Given this list of marker genes MAPK1IP1L, FOXL2NB, NEK2, GOSR2, SLC6A11, SATB2, PNPO, AAK1, C16orf54, CEP97, ETFBKMT (NCBI Gene Id 254013), MATR3, SYT4, CNTLN, LPGAT1, GINS1, IRF9, MYO5C, EFR3B, TSPAN2, FZD3, ORAI3, PNISR, TMEM170B, GNS, SERTAD2, IRF4, ALG1, CISD2, CDC5L, EEA1, TVP23A, C2orf49, CYP20A1, PSPH, H6PD, FDXACB1, ALDH18A1, RLIM, TKT, PIK3CA, GPI, SULT1E1, PPM1A, ZSWIM4, INTS6, TMEM52B, TRAPPC2, IGF2BP3, SLC4A8, SULT1C4, PAIP2B, PSTPIP2, MTPAP, SLAIN1, ZNF839, ZCCHC14, DCUN1D1, THUMPD2, FBXW2, HP1BP3, NPAP1, ZC3H6, CCL16, AMER2, KCNJ14, RPP30, TAS2R14, HUS1 (NCBI Gene Id 3364), RPS27L, CRIPTO, INMT, LEPROTL1, GOLM2, ZNF281, AS3MT, GLG1, AKR1D1, GRSF1, RBM8A, IFI6, PARD6B, CYP51A1, ARID5B, SLC5A5, SMC1A, SIKE1, MTFMT, UBE2W, EDEM1, KIF18B, OSBPL10, PIWIL1, CASTOR2 (NCBI Gene Id 730322), TOPORS, CBX5, REPS2 (NCBI Gene Id 9185), PRR27, ALDH16A1, TANGO2, DOCK1 (dedicator of cytokinesis 1), HELLS, EPB41L4A, SCIMP, ELAVL2, ZNF426, KL, MDM2, DUSP19, TMEM120B, FAM228B (family with sequence similarity 228 member B), HIF3A, SCARF1 (scavenger receptor class F member 1, NCBI Gene Id 8578), ZC3H13, RASSF5, STON1, DCUN1D2, TVP23C, CHSY3, WDR44, RBBP4, FBXL20, ZNF286B, COX15, PIGR, XPNPEP3, CHSY1, KRT222, MYLK4, SVBP, TLCD4, MOB1A, ZNF816-ZNF321P, APOL2, CREB1, SKA2, ZNF611, PTEN (NCBI Gene Id 8037), GTPBP3, NLRC3, KRIT1, HIGD1A, TRAF3IP1, TRIM59, FAM234B, HDAC2, PITPNM2, CHP1, RAB33B, EEF1AKMT3, PCDH10, DTX3L, EXOC5, SLC36A2, PSMD12, PURB, ZNF552, ENAH, WDR5B, ATP6V0A2, ZNF454, TNFSF9, KRR1, DNAL1, PDZD8, MED17, DHRSX, TMX1, NLK, ZNF780B, RBM43, MORN4, NIM1K, SLC8A1, SSX2IP, KBTBD6, KLF5, BAZ1A, POLR1G, TASOR, APOL6, SLC41A2, SLU7, ZSWIM1, ZNF850, VIP, UPK3BL1, STRADB, RTKN2, PGR, PPP1R15B, NUGGC, PLEKHA5, NCAPG2, BVES, FRG2C, SLC15A5, ZNRF3, RETREG3, RAB11A, ST8SIA4, C2orf69, HEG1, TM4SF20, SPACA9 (sperm acrosome associated 9), ZNF260 (zinc finger protein 260), PI4K2B, ZBTB2, CDCA7L, KIN, PDK3, SNTB2, SERPINB8, LRPPRC, MCM4, TLCD2, TOGARAM1, RTCA (NCBI Gene Id 8634), COLEC10, CYP4F3, RHNO1, MAVS, AIFM2, POLR2J3, DCP2, CBX6, MGA, MRPS30, FAM20B, PDE7A, SGCB, FYB2, UQCC3, TMEM184C, PAFAH1B1, HAVCR2, ZCCHC8, FGD5, CSGALNACT2, USP33, TPM3, ARCN1, ZNF326, TFAP2C, FLRT2, ZMYM6, ISL1 (ISL LIM homeobox 1), WAC, EEF1A1, DCAF17, PPM1D, ARL6IP1, TOR1AIP2, TRMT9B, EIF2S3, GABRP, DCUN1D5, LSM8, MYO3B, SALL4, CRCP, ICE2, TBK1 (NCBI Gene Id 29110), TIMM50 (translocase of inner mitochondrial membrane 50), CFL2, ZNF626, SINHCAF, RASGRP4, PIP4K2A, RRP15, OSMR, GPR37L1 (G protein-coupled receptor 37 like 1), SLC35E2A, GALNT12, GCM1, ZNF530, MFSD4A, PPFIBP1, OR2H1, MRPS16, TRPM6, TSPYL1, CHD6, TFDP2, S1PR5, TCF7, SCD, ELF5, RHD, SDHA (NCBI Gene Id 6389), ALDH6A1, LETM1, CENPA, DBT, ZC3H12B, POU2F3, KLF8, ZFP14, ARPIN, KHDRBS2, AIG1, UTP25, ACOX1, TAS2R20, PCBD2, ZNF793, NMNAT1, SLC19A4P, VIPR2, HMBOX1, VCPIP1, SUMF2, ZNF736, BPNT2, ACTR2, KPNA4, STAM, CA8, BCL10, TXNIP, HAUS5, ARL17A, RAD51AP2, MOB3B, RARS2, ILDR2, SNX22, SERPINB9, CACNG4, GOLGA3, MYLK3, CALCB, KIF3A, COLCA1, GXYLT1, TXNL4B, SURF4, GLB1L3, RNF125, PLAC8, BBIP1, SCD5, KPNA3 (NCBI Gene Id 3839), CEP72, CEBPB, AP1G1, NDUFV3, SLC48A1, COMMD8, FNBP4, DUSP3, ZNF486, ARGFX, GCSAML, SLC25A34, WDR27, PDE12, ZSCAN9, ABHD18, PTCHD4, ERCC6L2, CEACAM8, ZNF493, MEFV (NCBI Gene Id 4210), SLC15A1, ZNF814, EMC1, EMP2, ZBTB7A, TWF1, TXNDC9, MRPL19, TMED5, ADPRH, TMEM239, SH3TC2, LRRC47, PAICS, FZD2, FTO, MS4A10, FGFBP3, HS3ST3B1, FAM111A, RIMKLB, ELOVL5, TGS1, ZFP36L2, HOOK3, FXN, CEBPZOS, NOM1, RRM2, NDUFC2, SNX1, SDE2, POLH, EPHA3, USF3, AP4S1, RTBDN, INHBE, TENM2, GNG4, TNS4, ALG9, TIPRL, GNG2, CSDE1, RNF207, NHLRC2, ZNF101 (zinc finger protein 101), DIAPH2, VPS26A, ZNF785, SMAD4, MTR, PTGIS, ACKR2, RNF8, BRIP1, PRELID2, KALRN, NF2, ZNF286A, CDKL5, BRD2, TMEM167B, CCNJ, ZNF587B, PPAT, RAP1A, CR1, TMED4 (NCBI Gene Id 222068), SPATS2L, SLC9A7, ACYP2, INPP5B, RAD52, GTF2IRD2B, TMEM106B, MTX3, SV2B, FAM210A, CCNY, ADAMTS4 (ADAM metallopeptidase with thrombospondin type 1 motif 4), ZNF124, CSTF2T, VHL (von Hippel-Lindau tumor suppressor), HECW2, CILK1, HPSE, CAMLG, CDX1, GM2A, SMIM17, TMEM59, METTL8, PWWP3B, ZNF805 (zinc finger protein 805), RAD54B, ALKBH5 (NCBI Gene Id 54890), SLC25A32, SPRYD4, RPL15, SLC2A4 (NCBI Gene Id 6517, solute carrier family 2 member 4), FAM204A, KIF16B, GEMIN5, MAP4, ATL3, TMEM41B, TERF2, ZMYM1, PRTG, MFSD8, UBE2V2, ZNF699, PDE6B, SYNJ2BP, ARHGAP5, LY75, MPV17L, SDC2, APRG1, OLFML1, GRM3, TSNAX, SPECC1, HRH4, CDH6, FCAR, ZNF765 (NCBI Gene Id 91661), DAND5, PAPLN, HTR1D, CBL, WDR76, POLR2J2, TRDN, ELK4, CNBP, CFAP210, APOOL, FGF14, C19orf12, RBL1 (NCBI Gene Id 5933), ZBTB3, THAP5 (NCBI Gene Id 168451), PCDHB16, ATP13A4, SIX4, PHF20L1, SH3BGRL2, CGNL1, PPM1K, SIGLEC14, PTGES3L, SOAT1, TENM3 (NCBI Gene Id 55996), KIAA1210, ARSB, PHACTR4, SLC25A45, TRIM5, MOCS3, ALS2, STON2, SLC30A5 (solute carrier family 30 member 5), NSL1 (NSL1 component of MIS12 kinetochore complex), CHRDL1, PLA1A (NCBI Gene Id 51365), ZNF709, SLC12A8, ARMCX3, TRAF3IP2, HMGN2, ATRX, SLC17A3, STX11, SKA1, SLC16A7, NUDT19, CYB5R3, SPC24, LIX1L, SLC34A2, CLCC1, SUPT7L, LRRC19, ZNF543, GPATCH2L, AEBP2, RCN2, LZIC, GNL3L (G protein nucleolar 3 like), GABPA, RIT2, SFR1, GCOM1, ATXN7, ZSCAN2, KRBOX4, CNOT6L (NCBI Gene Id 91275), SERPINB1, TTN, MFSD14B, DICER1, SPN, SERF1B, ZFC3H1, TMTC1, UNC80, VENTX, ZNHIT6, UTP11, MAPK8, CYP2B6, CCDC141, SLA2, GSPT2, SHOC2, WNK3, CSK, ZNF527, CPS1, CPA4, SLC16A4 (solute carrier family 16 member 4), ZNF816, RMDN1, SHOX, TRIM16, LRRC28, FEZ1, GPR83, MRI1, HOGA1, TRIM13, TENT4B, MPIG6B, SNIP1, CYP1A2, TRIM16L, KIAA1143, PLEKHF2 (pleckstrin homology and FYVE domain containing 2), CLDN12, NEPRO, IRGQ, GAPVD1, ZBTB8OS, TOP3A, ARHGAP35, WDR87, RSKR (ribosomal protein S6 kinase related), TAF8, DACT2, ACACB, GNA13, SHCBP1, ELAPOR1, S1PR2, LAMP2, KLHDC1, VMP1, CREBZF, PDHA1, ATP1B4, ITGB8, AUNIP, ATXN3, SLC13A1, FNDC3A, STRIP2, NEXMIF, TCTN2, ZDBF2, RAD54L2 (NCBI Gene Id 23132), NOL9, LMTK2, TAB3, STMP1, TULP4, STEEP1, ZNF264, TRPM7, MRPS11, ANGPT4, STIL, SYT15, DNAJC14, WDFY1, THOC3, MSMO1, FRG2, ZNF681, E2F2, FAM117B, SGPL1, P2RY1, STX2, CREB5, MBOAT1, ZNF568, FSBP, ZNF28, ZCCHC4, NDUFC2-KCTD14, NCCRP1, RP2 (NCBI Gene Id 6102), LRP2BP, SCAF11, VPS13C, LILRA5, SNAPC3, LINC02897, CASP2 (NCBI Gene Id 835), SKP2, ZCCHC24, ZNF100, HACD2, TMEM33, NDRG3, SNX13, SOX4, GSTCD, SCAMP1, ZC3HAV1, NDUFA4 (NCBI Gene Id 4697), GTF3C4, SAMD4A, MGAT4A, CLSPN, CIPC, UCK2, DHH, STEAP4, VPS33B, MAST3, CPSF2, PLAAT5, MLANA, CAND1, SPIB, C2orf68, DISC1, FBXL17, CA5B, RBMS3, KLHL30, SART3, PURA, ZNF578, CCSER2, DENND1B, FRZB, SAR1B, C5AR1, TRPV1, ME2, SS18, QPCTL, MCTS1, EPG5, BAG5, PEAK3, ACTN4, TGFBR1, ZNF557, F3, APOBEC3D, CEP15 (centrosomal protein 15), ST6GAL2, SPAG9, FOXP2, GKN2, OLR1, PCDHB9, SMU1, SLC10A7, OLFML2A, OGFRL1, MS4A2, TIMM23B, CCDC50, C21orf91, ZNF845, KIF5C, SLC35F6, FOXK1, GSR, NR5A2, AADAT, PATJ, PABPC5, TPMT, LRPAP1, EPB41, LRRC51, SMUG1, SCN9A, FRMD8, KDM1A, RAB21, CACNA1D (calcium voltage-gated channel subunit alpha1 D), CD274, CCDC65, RBSN (rabenosyn, RAB effector), ARF4, ZNF808, FDFT1, ZBTB25, SEC63, CNOT6, OR51E2, PCDHB11, FAM114A1, PYGO1, RLF, ADAMTS18, CCDC122, ZNF490, ZNF621, NCBP3, IFNAR2, FBXO44, CYLD, SVOP, ATF1, MFAP3L, COX18 (cytochrome c oxidase assembly factor COX18), R3HDM2, LATS1, TFCP2L1, SH3D19, IYD, UHMK1, NPIPB13, OCLN, KLLN, ANKS4B, G6PC1, DCDC1, DBR1, MPC2, ZNF595, GTF2IRD2, VPS53, HPS3, FABP7, ANKRD17, ACTR10, APPL1, VSIG10, ZNF600, LYRM7, GATD1, EIF4E, SERF1A, LONRF2, ADIPOQ, KMT5B, FUS, TENM4, FGF12, TRIAP1, SPAST, CCNT2, MRFAP1 (NCBI Gene Id 93621), ZNF22, WDR55, METTL6, XIAP, SCN3B, C15orf40, MBD4, ZNF221, SYNPO2, PIGW, GNB4, PRKCI, SERBP1, SLC24A4, PLEKHH2, UBA5, GRB14 (growth factor receptor bound protein 14), IPMK, FGD2, ATAD5, MACO1, TBCB, TOR1B, LURAP1, GSDMA, SENP5, BLOC1S2, MSS51, UMPS, ITGAX, MAP7D3, ZNF587 (NCBI Gene Id 84914), NOCT, MLEC (NCBI Gene Id 9761), ZNF451, POLR2M, HYKK, ZC3HAV1L, TEDDM1, ARFIP1, DSCAML1, GPANK1, TRA2B, OPRK1, CD226, ZNF253, ANO6, PHLDA1, TNFRSF10B, ENPP1, RHPN2, TBC1D7, MDM1, CRIPT, LSM11, CLEC7A, RASGEF1A, COX6B2, RYR2, GUCY1A2, MCCC2, FAM217B, KCTD14, PDP2, ATF7IP, TXNRD2, CEP70, IBA57, PRR23A, UBE2K, ZNF770, C3orf70, ARAP2, IKZF1, CNBD2, APOBEC3F, MRO, TIMM10B, INSYN1, ASPN, IKZF3, NIBAN1, FANCF (NCBI Gene Id 2188), HECA, AFG2A, MARVELD2, MTRR, SUSD5, FKBP11, MTHFD2L, CHMP1B, PIK3CD, ZNF7, JAK2, NUFIP2, JAK3, FBXO28, SIGLEC11, RPS24, PHTF2, STAT2, NAIF1, ABCA5, WHAMM, AFMID, PTER, PAPOLG, RNF115, SCML2, PPP4C, CRTAP (cartilage associated protein), FSIP1, UBA52, SGCD, SLC24A1, TMF1, GPN3 (NCBI Gene Id 95310), CYP8B1, CD3G, UTP20, SERPINB13, RPL34, MDM4, SCAI, BLNK, RGS9BP, TAPBP, REEP3, here is a description of the gene set: Genes predicted to be targets of miRBase v22 microRNA hsa-miR-373-5p in miRDB v6.0 with MirTarget v4 prediction scores > 80 (high confidence targets). from publication Chen Y, Wang X (PMID 31504780) Human Gene Set: MIR373_5P studied in species Homo sapiens